Given this list of marker genes Fgf17, Fgf2, Kras, Fgf4, Fgf6, Grb2, Fgf18, Fgf10, Fgf22, Fgf5, Fgf23 (NCBI Gene Id 64654), Fgf20, Fgf3, Shc1, Fgf16, Fgf9, Fgf8, Hras, Fgf1, Sos1, Fgf7, here is a description of the gene set: Mouse Gene Set: REACTOME_SHC_MEDIATED_CASCADE_FGFR2 SHC-mediated cascade:FGFR2 species: Mus musculus